The following is a description of a gene set: studied in species Homo sapiens Either of the ends of a mitotic spindle, a spindle that forms as part of mitosis, where spindle microtubules are organized; usually contains a microtubule organizing center and accessory molecules, spindle microtubules and astral microtubules. Human Gene Set: GOCC_MITOTIC_SPINDLE_POLE, and this is the list of marker genes: OR2A4, HSF1, FAM83D, MAPKBP1, KATNBL1, AURKA, AURKB, TNKS, SPAG5, GPSM2, YPEL5, NIN, SMC3, SMC6, NSMCE1, RAE1, CDK5RAP2, IK, KATNA1, PLK1, MAPRE1, RMDN2, STAG1, RMDN1 (NCBI Gene Id 51115), CNTRL, ASPM, KIF20B, MAP10, SMC1A, BCCIP, STAG2, ARHGEF7, FAM161A, GIT1, KAT5, EML1, RMDN3, NUMA1, MAD1L1